The following is a description of a gene set: Any process that results in a change in state or activity of a cell (in terms of movement, secretion, enzyme production, gene expression, etc.) as a result of stimulus by estradiol, a C18 steroid hormone hydroxylated at C3 and C17 that acts as a potent estrogen. species: Mus musculus Mouse Gene Set: GOBP_CELLULAR_RESPONSE_TO_ESTRADIOL_STIMULUS, and this is the list of marker genes: Hnrnpd (NCBI Gene Id 330135), Sfrp1, Sstr1, Pou4f1, Fam210b, H2az1, Myog, Crhbp, Ramp3, Bcl2l2, Lcor, Hsf1, Nrip1, Msx2, Esr2, Aifm1, Ncoa3, Egfr, Ccna2, Sstr2, Ugt1a1, Esr1, Gper1, Ccdc62 (NCBI Gene Id 639165), Ccl2, Il10, Myod1, Sstr3, Ruvbl2, Itga2, Ppp1r9b, Pou4f2, Mmp2, Zfp703, Abcb1a, Kat5, Kif18a